Given this list of marker genes TRAPPC9, ASXL3, EBF3, INTS1, GEMIN4, MDH1, GRM1, VLDLR, BRF1, KIAA0753, PIEZO2, L1CAM, LAMA1, BMP4, MED11, ACBD6, here is a description of the gene set: studied in species Homo sapiens Human Gene Set: HP_INFERIOR_CEREBELLAR_VERMIS_HYPOPLASIA Underdevelopment of the inferior portion of the vermis of cerebellum. Inferior cerebellar vermis hypoplasia